Given this list of marker genes LILRA4, TREML4, TLR7, SCIMP, TASL, UNC93B1, HAVCR2, PIK3AP1, DDX3X, SLC15A4, RSAD2, here is a description of the gene set: The series of molecular signals initiated by a ligand binding to the endolysosomal toll-like receptor 7. studied in species Homo sapiens Human Gene Set: GOBP_TOLL_LIKE_RECEPTOR_7_SIGNALING_PATHWAY